The following is a description of a gene set: species: Homo sapiens Reactome Pathway: Diseases of Base Excision Repair Germline mutations, single nucleotide polymorphisms (SNPs) and somatic mutations in several genes involved in base excision repair (BER), a DNA repair pathway where a damaged DNA base is excised and replaced with a correct base, are involved in the development of cancer and several other oxidative stress-related diseases. For review, please refer to Fu et al. 2012, Fletcher and Houlston 2010, Brenerman et al. 2014, Patrono et al. 2014, and D'Errico et al. 2017. part of: Diseases of DNA repair, and this is the list of marker genes: NEIL1, NEIL3, OGG1, MUTYH, NTHL1